The following is a description of a gene set: Human Gene Set: GSE17721_CTRL_VS_PAM3CSK4_12H_BMDC_UP mouse primary BMDCs were stimulated with tlr ligands and gene expression changes were profiled on Affymetrix arrays from publication Amit I, Garber M, Chevrier N, Leite AP, Donner Y, Eisenhaure T, Guttman M, Grenier JK, Li W, Zuk O, Schubert LA, Birditt B, Shay T, Goren A, Zhang X, Smith Z, Deering R, McDonald RC, Cabili M, Bernstein BE, Rinn JL, Meissner A, Root DE, Hacohen N, Regev A (PMID 19729616) Genes up-regulated in comparison of control dendritic cells (DC) at 12 h versus those stimulated with Pam3Csk4 (TLR1/2 agonist) at 12 h. species: Homo sapiens, and this is the list of marker genes: PROSER2, VOPP1, MPP7, MED22, SSBP2, LPGAT1, CRYBG3, HAUS8, HLA-DMA, ITM2B, FAM111A, PAPOLG, MRPS15, EML5, CLDN6 (NCBI Gene Id 9074), COX4I1, PKP3, CDKAL1, ZNF574, SYNPO, IRAG2, PLCL2, OSBPL2, KCTD11, CFAP68, WWOX, MAZ, PTPRS (protein tyrosine phosphatase receptor type S), GAB2, JUP, MMD, TCN2, MBP, FBXL12, GPR35 (G protein-coupled receptor 35), GLUL, SIDT2, PIK3C2A, ADAM10, PTDSS1, GTF3C2, IVNS1ABP, GADD45G, ANLN, MEF2D, HIGD2A, PTPN21, FDFT1, MRPS24, TNFRSF21, IRF2, SYN2 (synapsin II), XBP1, ABCA2, ATP5PF, SLC29A3, CD164, VDAC1, LCMT1, CLYBL, GUSB, SRMS, ATP8B3, UBP1, PPP3CA, MCM7, RCOR3, ADSS1, LARGE1, RAD51, EXT2, KLRK1, CCNA2, SCN11A, LAPTM4A, ANGPTL6, SV2A, AKR1B10, HIF1A, HADHB, F8A1, SSR4, NDUFV3, PSME3IP1, SEMA6C, HADH, RPL13, SPRR2F, ACOX2, MKNK2, PNPLA7, HNRNPLL, GRN, ATP5F1A, ITFG1, BECN1, SCNN1A, BSPRY, GALC, SH2B2, FUCA2, SLC25A20, NLK, ENC1, SLC25A46, GSTK1, SLC50A1, TRIM59, LDLRAP1, SLC17A9, COMMD5, PNRC1 (NCBI Gene Id 10957), VPS54, ZBTB1, CDK1, PRELID1, CHCHD7, SUPT4H1, SELENOP, SPICE1, XPR1, TMEM121B, DNMBP, UNC119B, MSH6, MFSD6, PRXL2A, BCAP31, HNRNPU (NCBI Gene Id 3192), ENTPD1, OXR1, PTPN18, FLCN, ZIM3, MDH1, OGFOD2, TF, ADISSP, CHMP1B, VRK1, MUL1, PNPO, CCNT2, RNF13, ATG3, CARHSP1, TADA1, ZFYVE19, IDH3A, CPPED1, TMEM131L, APPL2, NANS, TESK2, WDR45, SDHC, CD300C, N4BP3, GASK1B, NQO2, HPCAL1, LEPROT, NSMCE1, XPC, BDH1, ZNF277, COL11A1, PTPRZ1, ELOVL6, HEBP1 (heme binding protein 1), CYTH1, TECR, RAB38, HACE1, TIMM10B, YPEL3, TNFRSF18, PPIH, RABAC1, CTSH, HMGCS1, ZFAND1, ADCY4, PLEKHF1, ADK, KCTD20, EMP3, RASSF5, IFI30, GSTZ1, AUH, SLC25A4, SOCS6, HSCB, NAXE, CENPQ, TANGO2, LGI1, TERT, PLA2G15